The following is a description of a gene set: The process in which ions are transported across the plasma membrane of a ventricular cardiac muscle cell such that the membrane potential changes in the repolarizing direction, toward the steady state potential. For example, the repolarization during an action potential is from a positive membrane potential towards a negative resting potential. Human Gene Set: GOBP_VENTRICULAR_CARDIAC_MUSCLE_CELL_MEMBRANE_REPOLARIZATION studied in species Homo sapiens, and this is the list of marker genes: NOS1, KCNE5, CAV3, WDR1, KCNH2, KCNE4, RNF207, DLG1, KCNE2, CASQ2, AKAP9, KCNH6, ANK2, CACNA2D1, ZMPSTE24, KCNQ1, MIR133A1, SCN4B, SNTA1 (NCBI Gene Id 6640), KCNJ3, GJA5 (gap junction protein alpha 5), SCN5A, KCNE1, NOS1AP, KCNE3, MIR1-1, SCN2B, KCNJ5, KCND3 (NCBI Gene Id 3752), SCN1B, KCNJ8